Given this list of marker genes Tmem64, Calb1, Ncs1, Chga, Tmem178, Cav3, Erc2, Tspoap1, Atp2b4 (NCBI Gene Id 381290), Gpr3, Calcb, Cacna1d, Grin2b, Erc1, Cav2, Plcd1, Trpc1, Atp2b2, Trpc4, Slc8a2, Hcrtr1, Ryr2, P2ry4, Cnga1, Atp2b3, Tunar, P2ry2, Grid2ip, Trpc2, Rimbp2, Wnt5a, Calca, Htr1b, Myo5a, Cdk5, Fxyd1, Npy, Slc8b1, Trpc5, Trpc3, Ryr1, Fto, Trpc6, Marcksl1, Cacna1a, Gper1, Grm1, Cul5, Adcy8 (adenylate cyclase 8), Fxn, Trpc7, Slc35g1, Cacnb4, Fzd9, Cngb1, Osbpl2, Hrc, Cnr1, P2ry1, Npy1r, Asph, Hcrtr2, Cacnb2, Calb2, Cdh23, P2rx2, Sv2b, Kcnh1, Ywhae, Synpo (NCBI Gene Id 77694), P2rx1, Atp2b1, Cav1, F2, Cln3, Bok, Adora1, Myh7b, Itpr1, Tex101, here is a description of the gene set: Any process involved in the maintenance of an internal steady state of calcium ions within the cytosol of a cell or between the cytosol and its surroundings. Mouse Gene Set: GOBP_REGULATION_OF_CYTOSOLIC_CALCIUM_ION_CONCENTRATION species: Mus musculus